Given this list of marker genes Sox9, Mustn1, Lef1, Six2, Pbxip1, Comp, Ltf, Scube2, Sirt6, Dspp, here is a description of the gene set: species: Mus musculus Mouse Gene Set: GOBP_POSITIVE_REGULATION_OF_CHONDROCYTE_PROLIFERATION Any process that increases the frequency, rate or extent of the multiplication or reproduction of chondrocytes by cell division, resulting in the expansion of their population. A chondrocyte is a polymorphic cell that forms cartilage.